The following is a description of a gene set: Fumarate hydratase-deficient renal cell carcinoma (FH-deficient RCC) is a rare yet highly lethal kidney cancer. To deepen understanding of FH-deficient RCC, the authors conduct a comprehensive integrated genomic study. The authors analyze the association of FH alteration patterns with tumor heterogeneity and develop a CpG site-specific methylation signature for precise identification of FH-deficient RCC. Transcriptomic analysis unveils three distinctive molecular subtypes characterized by enrichment of immune/Angiogenic/Stromal (C1), WNT/Notch/MAPK (C2), and proliferation/stemness (C3) pathways, respectively. Tumors in C1 derive the most substantial survival benefit from a combination of immune checkpoint blockade (ICB) and anti-angiogenic therapy. Tumors in C2 display moderate response to this therapeutic approach. In contrast, tumors in C3 exhibit an unfavorable response to anti-angiogenic monotherapy and its combination with ICB. These findings contribute to a profound understanding of the aggressive nature of FH-deficient RCC, offering insights into potential precision medicine approaches for disease management. from publication Zhang X, Zhao J, Yin X, Liang J, Wang Y, Zheng L, Tan P, Lin Y, Xu N, Zhu S, Chen J, Zhao J, Hu X, Pan X, Nie L, Zhang M, Chen Y, Zhang Y, Liu H, Dai J, Wang Z, Liu H, Ni Y, Rupp NJ, Moch H, Sheng X, Gong K, Liu X, Chen Z, He Z, Wang Y, Xu L, Liu M, Zhou H, Tang B, Huang R, Wei Q, Li X, Liu J, Yao J, Liao B, Liu Z, Shen P, Chen N, Zeng H, Sun G (PMID 40355427) Human Gene Set: ZHANG_FH_DEFICIENT_RCC_C2_VS_OTHERS_UP studied in species Homo sapiens Genes upregulated in the C2 subtype of FH-deficient RCC relative to C1 and C3 subtypes., and this is the list of marker genes: ESPN, C10orf53, DERPC, CNGA3, IHH, KRT75, PAX3, ADGRA1, SAG, HTR5A (NCBI Gene Id 3361), OR8B8, ZNF556, FRMD7, EPPK1, HELT, LCTL, BPIFB3, PNMA5, OR2T3, VSIG8, LRFN2, BARX1, SYCE1L, SLC4A9, OR3A2, OR6P1, MS4A8, CLEC18C, C1orf202, MPO, MFRP, OR5A1, OR4K2, ENSG00000283599, HS3ST6 (heparan sulfate-glucosamine 3-sulfotransferase 6), PLIN5, ADGRG4, OR5AS1, HRH3, SYCP1, TMEM207, ADGRD2, CAMKV, PHOX2B, IRX1, CACNG4, LARGE2, CHCT1, UNCX, HAO1, C10orf71, MMD2, SALL3, KRT6A, OPRM1, ITLN2, CEL, MYL2, CATSPER4, DSG3, SLC12A3, CLCNKA, SSX5, SLC18A3, SVOP, TMEFF1, MMP20, OR5T2, PIWIL3, OR10H1, OR10K2, SLC17A6, KRT35, ZDHHC22, PAX4, CALML3, DMRTB1, IRX4, PCYT1B, C1orf167, GABRA1, OTC, PAX7, ALKAL1, PRAMEF1, CACNG5, CHRNA4, DMRTC2, CCER1, GCGR, TCP10L3, OR51A4, SMYD1, SLC6A5, DMRT2, AQP6, PTGER1, TAF1L, CPA2, SOWAHA, SRARP, FTCD, SLC26A3, GPR149, SPATA3, SEPTIN12, KPRP, ODAM, OR52N1, FGF4, MUC2, OR52E6, GRM4, FBN3, OR4A16, MT3, DUSP9, OR11G2, PRR27, LMX1A, NEUROD1, KRT78, KRT3, CTCFL, SKOR2, GRK1, HOXB13, BTBD17, FKBP6, BEND2, OR2T34, HMX2, MGAT4D, SYT12, SRRM4, KCNA1, MUC21, FAM181B, MPPED1, NHLH2, SERPINB13, REG1B, OR2T29, CLCNKB, ATP1B4, AMN, KLHL1, AQP5, B3GNT6, KRT2, TEX13C (NCBI Gene Id 100506663), INSRR, PRR35, TMDD1, LGALS9C, MSMB, SOHLH1, TMEFF2, AMER2, ADAM30, LRIT1, CFAP107, OVOL1, TFAP2D, ANKRD63, GALNTL5, KLK2